Given this list of marker genes Hnmt, Pnmt, Tpmt, Comt, Mat2b, Inmt, Mat2a, Mat1a, Nnmt, here is a description of the gene set: Mouse Gene Set: WP_METHYLATION studied in species Mus musculus Methylation